The following is a description of a gene set: Reactome Pathway: Pyroptosis electronically inferred by orthology from the curated human pathway part of: Regulated Necrosis species: Mus musculus This event has been computationally inferred from an event that has been demonstrated in another species.<p>The inference is based on the homology mapping from PANTHER. Briefly, reactions for which all involved PhysicalEntities (in input, output and catalyst) have a mapped orthologue/paralogue (for complexes at least 75% of components must have a mapping) are inferred to the other species., and this is the list of marker genes: Il1a, Chmp2b, Bax, Gsdmd, Gzmb, Chmp2a, Elane, Casp4, Casp3, Cycs, Hmgb1, Bak1, Casp1